The following is a description of a gene set: This event has been computationally inferred from an event that has been demonstrated in another species.<p>The inference is based on the homology mapping from PANTHER. Briefly, reactions for which all involved PhysicalEntities (in input, output and catalyst) have a mapped orthologue/paralogue (for complexes at least 75% of components must have a mapping) are inferred to the other species. Reactome Pathway: Metabolism of nitric oxide: NOS3 activation and regulation species: Mus musculus electronically inferred by orthology from the curated human pathway part of: Metabolism, and this is the list of marker genes: Cyb5b, Cav1, Calm1, Dnm2, Nosip, Zdhhc21, Lypla1, Nostrin